The following is a description of a gene set: studied in species Homo sapiens Human Gene Set: TONKS_TARGETS_OF_RUNX1_RUNX1T1_FUSION_SUSTAINED_IN_GRANULOCYTE_DN Genes down-regulated by RUNX1-RUNX1T1 fusion protein in normal hematopoietic progenitors; their expression was sustained in subsequently developing granulocytes. The t(8;21)(q22;q22) occurs frequently in acute myelogenous leukaemia and gives rise to the transcription factor fusion protein, RUNX1-RUNX1T1 (also known as AML1-ETO). To identify the genes dysregulated by the aberrant transcriptional activity of RUNX1-RUNX1T1, we used microarrays to determine the effect of this mutation on gene expression in human progenitor cells and during subsequent development. Gene signatures of these developmental subsets were very dissimilar indicating that effects of RUNX1-RUNX1T1 are highly context dependent. We focused on gene changes associated with the granulocytic lineage and identified a clinically relevant subset of these by comparison with 235 leukaemia patient transcriptional signatures. We confirmed the overexpression of a number of significant genes (Sox4, IL-17BR, CD200 and gamma-catenin). Further, we show that overexpression of CD200 and gamma-catenin is also associated with the inv(16) abnormality which like RUNX1-RUNX1T1 disrupts core binding factor activity. We investigated the functional significance of CD200 and gamma-catenin overexpression in normal human progenitor cells. The effect of IL17 on growth was also assessed. Individually, none of these changes were sufficient to recapitulate the effects of RUNX1-RUNX1T1 on normal development. These data provide the most comprehensive and pertinent assessment of the effect of RUNX1-RUNX1T1 on gene expression and demonstrate the highly context-dependent effects of this fusion gene. from publication Tonks A, Pearn L, Musson M, Gilkes A, Mills KI, Burnett AK, Darley RL (PMID 17898786), and this is the list of marker genes: FCER1A, CYP1B1, CAMK1, PMP22, ALOX5AP, IL10RA, HDC